The following is a description of a gene set: Reactome Pathway: Inhibition of TSC complex formation by AKT (PKB) part of: MTOR signalling Tuberous sclerosis complex (TSC) is a multi-system genetic disorder caused by loss of function mutations in one of the two tumor suppressors, TSC1 and TSC2, that form the protein complex known as the TSC complex, TSC1-TSC2, TSC1:TSC2 or hamartin-tuberin complex. The TSC complex regulates mTORC1 activity by acting as a GTPase activating protein (GAP) for the small GTPase RHEB. The TSC complex converts GTP-bound RHEB, which activates mTORC1, to an inactive GDP-bound form, thus inhibiting mTORC1 activation. Phosphorylation of TSC2 on multiple sites by AKT (PKB) relieves the inhibitory effect of the TSC complex on RHEB. AKT-mediated phosphorylation affects TSC2 function in at least two ways: first, phosphorylation decreases the activity of TSC2; second, phosphorylation destabilizes the TSC2 protein. This destabilization is achieved by disrupting complex formation between TSC1 and TSC2 and inducing ubiquitination of the free TSC2. Phosphorylation of complexed TSC2 by AKT may result in the dissociation of the TSC1:TSC2 complex. On the other hand, the TSC complex attenuates a regulatory negative feedback loop in which mTORC1-activated S6K1 (RPS6KB1) inhibits insulin-mediated activation of PI3K/AKT signaling and can promote tumorigenesis in some cancer types. species: Homo sapiens, and this is the list of marker genes: TSC1, AKT2, AKT1 (NCBI Gene Id 207), AKT3, TSC2